Given this list of marker genes CHRNB4, NOS1AP, PPARGC1B, DEAF1, ACADM (NCBI Gene Id 51779), IL10, PHOX2A, PRKAR1B, BHLHE40, HDAC9, TP73, HDAC1, HSPD1, MAP2, EP300, NFKB1, CAV3, CTNNB1, VAMP2, PRKACA, CHRNA4, PRKACB, SLC1A3, KCNH2, NFYA, GCK, GNB3, ALDOA, DDC, MIR130A, SLC25A4, NTRK2, VIPR1, VEGFA, PHOX2B, IL1B, FMO3, IL6, MECP2, MIR210, TPH2, POU2F2, SSTR2, NFKB2, GJA1 (gap junction protein alpha 1), IL6R, HES1, GRIN1, NEUROD1, SSTR1, CPT1A, CHRM2, TACR1, THRB, CC2D1A, CREB1, GABRA1, SST, TCF3, TSPYL1, SLC6A4, CREM, FEV, SCN4B, ADCYAP1R1, CHAT, SCN5A, CTCF (NCBI Gene Id 10664), YWHAH, NANOG, YWHAQ, TLX3, RET, NKX2-2, CREBBP, BDNF, SCN3B, EGR1, YWHAB, SOX2, SNAP25, MIR16-1, ESR2, PRKAR2A, G6PC1, SPTBN1, HSP90B1, YWHAE, YWHAZ, C4A, NGF, PAH, RYR2, MBD1, IL1A, VIPR2, C4B, EN1, PBX1, HTR1A, HTR2A, CASP3, GATA2, SNTA1, SP3, YWHAG (NCBI Gene Id 96443), MAZ, HIF1A, TPH1, ADCYAP1, TAC1 (NCBI Gene Id 6864), HES5, PRKAR2B, SP1, PRKAR1A, LMX1B, GPD1L, TH, AR (NCBI Gene Id 367), ECE1, KCNQ1, YBX1, HADHA, TNF, TPPP, GATA3 (NCBI Gene Id 84828, GATA binding protein 3), CHRNA7, REST, AQP4, DLX2, IL1RN, NR3C1 (NCBI Gene Id 389335), FOXM1, MYB, IL13, GAPDH, PPARGC1A, TF, ASCL1, HADHB, CHRNB2, CDCA7L, RUNX3, ATP1A3, RORA, KCNJ8, MEF2C, POU3F2, NKX3-1, JUN, PKNOX1, HTR3A (NCBI Gene Id 3359), PLP1, POU5F1, CEBPB, SLC9A3, MAOA, AVP, CXCL8, here is a description of the gene set: Human Gene Set: WP_SUDDEN_INFANT_DEATH_SYNDROME_SIDS_SUSCEPTIBILITY_PATHWAYS species: Homo sapiens Sudden infant death syndrome (SIDS) susceptibility pathways